The following is a description of a gene set: This event has been computationally inferred from an event that has been demonstrated in another species.<p>The inference is based on the homology mapping from PANTHER. Briefly, reactions for which all involved PhysicalEntities (in input, output and catalyst) have a mapped orthologue/paralogue (for complexes at least 75% of components must have a mapping) are inferred to the other species. studied in species Mus musculus Reactome Pathway: Activation and oligomerization of BAK protein electronically inferred by orthology from the curated human pathway part of: Intrinsic Pathway for Apoptosis, and this is the list of marker genes: Bak1